The following is a description of a gene set: Mouse Gene Set: GOMF_CYCLIC_NUCLEOTIDE_BINDING studied in species Mus musculus Binding to a cyclic nucleotide, a nucleotide in which the phosphate group is in diester linkage to two positions on the sugar residue., and this is the list of marker genes: Bves, Cngb3 (NCBI Gene Id 30952), Pde4a, Cnga1, Cnp, Prkg2, Hcn1, Cnga2, Pde4d, Pde10a, Popdc2, Slc19a1, Prkar1a, Hcn2, Pde2a, Pde5a, Sting1, Cngb1, Rapgef2, Pde1c, Pde6c, Pde6h, Pde4b, Prkar2a, Fkbp1b, Pde11a, Cnga3, Cnbd2, Cnga4, Pde6g, Hcn4, Rapgef4, Popdc3, Prkar2b, Kcnh1, Hcn3, Prkg1, Prkar1b, Rapgef3